Given this list of marker genes ARCN1, ID2 (NCBI Gene Id 3398), ID1, USP1, CDKN1A, here is a description of the gene set: Human Gene Set: WP_MIR517_RELATIONSHIP_WITH_ARCN1_AND_USP1 miR-517 relationship with ARCN1 and USP1 species: Homo sapiens